The following is a description of a gene set: studied in species Mus musculus The chemical reactions and pathways resulting in the formation of proteoglycans, any glycoprotein in which the carbohydrate units are glycosaminoglycans. Mouse Gene Set: GOBP_PROTEOGLYCAN_BIOSYNTHETIC_PROCESS, and this is the list of marker genes: Fam20b, Ext2, B3gat3, B3galt6, Hs3st6 (NCBI Gene Id 433086), Hs3st3b1, Ugdh, Chst12, B3gnt7 (UDP-GlcNAc:betaGal beta-1,3-N-acetylglucosaminyltransferase 7), Chst10, Bmpr2, Slc35b2, Hs2st1, Tcf7l2, Foxl1, Hs6st1 (heparan sulfate 6-O-sulfotransferase 1), B4galnt3, Slc2a10, Chsy1, Igf1, Cant1, Chst1, Chst5, Angpt1, Slc35d1, Glce (NCBI Gene Id 93683), Hs3st1, Dse (NCBI Gene Id 212898), Ctnnb1, Chsy3, Slc35d2, B3gat1 (NCBI Gene Id 76898), Chst13, Chst3, Hs6st3, Man1c1, Bmpr1b, Vangl2, Ndst2, Cytl1, Chst14, Chpf, Hs3st4, Xylt2, Extl1, Slc10a7, Ndst4, Csgalnact1, Csgalnact2, Hs3st3a1, Ndst1, B3gat2, B4galt4 (NCBI Gene Id 66823), Hs3st5, Lipc, B4galnt4, Chpf2, Chst8 (NCBI Gene Id 68947), Hs3st2, Galnt3, Xylt1, Tm9sf2, B4galt7, Ndst3, Acan, Mustn1, Pxylp1, Hs6st2, Ust, Chst9, Ext1, Chst7, Chst11, Extl3